Given this list of marker genes Ppfia4, Tspoap1, Slc5a7, Chat, Rims1, Slc18a3, Unc13b (NCBI Gene Id 230089), Cplx1, Ppfia3, Ppfia2, Ppfia1, Stxbp1, Stx1a, Snap25, Rab3a, Syt1, Vamp2, here is a description of the gene set: Mouse Gene Set: REACTOME_ACETYLCHOLINE_NEUROTRANSMITTER_RELEASE_CYCLE studied in species Mus musculus Acetylcholine Neurotransmitter Release Cycle